The following is a description of a gene set: Any process that stops, prevents, or reduces the frequency, rate, or extent of interleukin-21 production. studied in species Homo sapiens Human Gene Set: GOBP_NEGATIVE_REGULATION_OF_INTERLEUKIN_21_PRODUCTION, and this is the list of marker genes: MIR21, MIR222 (microRNA 222), MIR221, MIR215 (microRNA 215), MIR192